The following is a description of a gene set: Human Gene Set: HP_REDUCED_VITAL_CAPACITY Reduced vital capacity An abnormal reduction on the vital capacity, which is defined as the total lung capacity (volume of air in the lungs at maximal inflation) less the residual volume (i.e., volume of air in the lungs following maximal exhalation) of the lung. species: Homo sapiens, and this is the list of marker genes: KBTBD13, MUSK, CHRNA1, ACTA1, RAPSN, CHRNE, MYH7, TTN, COL13A1, TPM3, CRPPA, MYPN, ACTN2, MYOT, TPM2, SBF2, PYROXD1, CHRNB1, MAP3K20, AK9, CHRND, AGRN, VCP, SELENON, NEB, LRP4, DOK7, SCN4A, KLHL41